The following is a description of a gene set: studied in species Mus musculus Any process that stops, prevents or reduces the frequency, rate or extent of intracellular signal transduction. Mouse Gene Set: GOBP_NEGATIVE_REGULATION_OF_INTRACELLULAR_SIGNAL_TRANSDUCTION, and this is the list of marker genes: Strn3, Rubcn, Igf1r, Sar1b, Ppp2r1a (NCBI Gene Id 76182), Dsg3, Prkdc, Nodal, Sla2, Cdc34, Csnk1a1, Gsk3b, Nme5, Pink1, Pttg1ip, Deptor, Smpdl3a, Hspa8, Kics2, Uchl1, Opa1 (OPA1, mitochondrial dynamin like GTPase), Bmp2, Ubr1, Gdf15, Cd44, Rnf152 (ring finger protein 152), Mecom, Map2k5, Dmd, Ifi203, C1ql4, Ufd1, Ppm1a, Ska1, Spi1, Cyrib, Tarbp2, Trim30a, Pde10a, Siglecg, Rasa2, Foxp1, Tmem161a, Myadm, Emilin1, Usp20, Minar1, Gpx1, Endog, Ska3, Tmc8, Trim15, Tpt1, Tnfaip3, Slc39a8, Arrb2, Magi2, Sfrp4, G2e3, Tbc1d7, Cptp, Gstp-ps, Rffl, Tkfc, Cyp2j6, Pdx1, Pebp1, Cavin3, Ifi208, Stk38, Pde2a, Drd3, Cep63, Zc3h12a, Atad3a, Ccn3, Dlg1, Aida, Vhl, Dusp7, Rps6ka6, Trim32, Ube3a, Nck1, Hipk3, Flcn, Arhgap24, Pkhd1, Grina, Vps18, Nop53, Tbk1, Foxo1, Usp10 (NCBI Gene Id 69204), Cdkn2a, Pten, Marveld3, Cyld, Nlk, Eid2, Cpne1, Them4, Fbp1 (NCBI Gene Id 14122), Prex1, Aars2, Smad4, Dynlt1b, Nr1h4, Wnk2 (NCBI Gene Id 75607), Spry4, Prkaca, Trem2 (NCBI Gene Id 83433), Nfe2l2, Dusp8 (dual specificity phosphatase 8), Stambp, Dusp26, Peli1, Btn2a2, Scai, Bcl6, Crebrf (NCBI Gene Id 77128), Tcf21, Ripk1, Igf1, Arhgap35 (NCBI Gene Id 65101), Rnf170, Ephb2, Eno1, Riok3, Sfrp2, Mefv, Tradd, Dyrk1a, Nlrx1, Ncor2, Akt3, Itfg2, Ski, Stmn3 (NCBI Gene Id 99032), Traf2, Lax1, Xbp1, Pik3ip1 (NCBI Gene Id 76083), Hdac3, Wtip, Tlr9, Armc10, Pik3r2, Ccar2, Ybx3, Tns3, Nf2, Dgkg, Fignl1, Heg1, Prkaa1, Pycard, Stat3, Dok2, Cd22, Tspan6, Inpp5k, Cnot9, Pdcd4, Uaca, Ndufa13, Pde3a, S2bpcox16 (synaptojanin 2 binding protein Cox16 readthrough), Veph1, Phb1, Sar1a, Slmap (NCBI Gene Id 83997), Cgnl1 (NCBI Gene Id 68178), Prdm15, Lilrb4b, Brca1, Pbp2, Rcan1, Rack1, Prkar1a, Szt2, Lilrb4a, Cdk5rap3, Lingo1, Psmd10, Errfi1, Prkar1b (protein kinase, cAMP dependent regulatory, type I beta), Ppp6c, Arhgap29, Nkiras2, Map2k3, Fhl2, Parp1, Pde11a, Trp63, Ifi207, Dyrk2, Hdac1, Zfp536, Wwc2, Pmepa1, Nono, Mapkap1, Rabgef1, Dhx58, Rnf149, Tmsb4x, Bag5, Dab2, Stmn1, Cyp26b1, Plekha1, D1Pas1, Park7, Ace2, Zdhhc12, Actn3, Spred2, Cnot1, Mad2l1bp, Cdkn2d, Fbxw11, Heyl, Rab7b, Abca7, Mif, Nppa, Hspb1, Lbh, Ifi206, Tnk1, Prkaa2, Ptgs2 (prostaglandin-endoperoxide synthase 2), Mir143, Dgkz, Huwe1, Tnip1, Rnf31, Tmem127, Wnt1, Adipoq, Rgs2, Cryba1, Rnf125, Selenos, C1qbp, Pik3cb, Trim31, Eno1b, Map2k1, Dusp6, Epm2a, Dusp2, Lyn, Hells (helicase, lymphoid specific), Spry2, Kank2, Ube2d1, Sh3glb1, Ddrgk1, P2rx7, Gstp1, Asxl1, Birc2, Ncor1, Edn1, Nlrp12, Cav1, Sesn2, Foxm1, Cmya5, Arhgap25, Xdh, Ptpn1, Ripor2, Ash1l, Prkcd (protein kinase C, delta), Nfkbil1, Itgb1, Drd2, Cry2, Nkiras1, Tgif1, Hdac7, Dnajb9, Ifi203-ps, Ppif, Ndrg2, Npc1, Prmt1, Bmal1 (basic helix-loop-helix ARNT like 1), Dusp5, Sco1, Hapstr1, Bfar, Inpp5e, Optn, Oprl1, Commd1, Serpine2 (serine (or cysteine) peptidase inhibitor, clade E, member 2), Insig2, Git1, Gper1, Eif2a, Ddx3x, Kdm1a, Dusp19, Ube2w (NCBI Gene Id 66799), Il1b, Parl (NCBI Gene Id 52663), Nol3, Wdr91, Arhgap42, Adra1b, Gata4, Mapk14, Mtor, Nck2, Shank2, Dok1, Myoz1, Ywhaz, Atad5, Stub1, Mob4, Gpatch3, Uri1, Itga3, Epo, Mndal, Fbxo7 (NCBI Gene Id 97657), Pbk, Muc1, Ikbkg, Dusp16, Pdia6, Mapk8ip1 (NCBI Gene Id 19099), Cilp, Tbc1d10c, Mapk3, Dusp13b, Lemd2, Cry1, Nlrc3, Otud3, Ddit4, Arrb1 (NCBI Gene Id 74110), Men1 (multiple endocrine neoplasia 1), Yju2, Rasip1, Src, Lmo3, Ifi35, Pp2d1, Ndufs3, Marchf7, Depdc5, Ogt, Dhrs3, Ucma, Vcp, Spred1, Cd74, Alg13, Smad7, Ndufc2, Timp2, Fam89b, Fzd1, Ptprc, Stat1, Pafah1b1, Rasal3, Triap1, Plaur, Phb2, Spred3, Clu, Cxcl12, Bdkrb2, F2rl1, Noc2l, Lztr1, Nherf4, Nprl2, Vdac2, Arhgap45, Ppia, Prnp, Cd300a, Aars1, Trim67, Sesn3, Castor2, Gpd1l, Ubqln1, Cntnap2, Rela, Smpd1, Lyplal1, Myoc, Prap1, Ppp1r10, Kctd10, Ptpn6, Ptprr, Rapgef1, Npy2r, Mapkapk5, Prex2, Dkk1, Cdc42se1, Erbin, Snai1, Mkrn2, Igtp, Trim39, Tnip2, Ppp2cb, Tsc2, Spaar, Gsk3a, Gmip, Sharpin, Cblc, Ackr3, Eif3a, Casp8, Gramd4, Isl1, Prkn, Pkia, Atf4, Ajuba, Ddias, Rtkn2, Chp1, Tnip3, Nfkbia, Ikbkb, Hyal2, Agt, Strip1, Irgm1, Atxn3, Cyp7b1, Abl1, Atf6b, Trim11, Prkacb, Hif1a, Sirpa, Trim59, Vrk3, Tnfaip1, Nlrp6, Aurka, Il10, Castor1, Creb3l1, Mmp9, Taok3, Nog, Tmbim6, Hmgcr, Snai2, Tsc1, Epha4, Plin5, Cul3, Sirt2, Sh2b3, Lif, Nfkbid, Homer2, Adgrg3, Tlr4, Egln1, Twist1, Vps11, Ell3, Dusp3, Sirt1, Plk3, Atp2b4, Styxl2 (serine/threonine/tyrosine interacting like 2), Sh3bp4, Gba1, Zmynd11, Nucb2, Map3k20, Rasal1, Thbs1, Zfp366, Slc24a4, Lrp1, Epha7, Mad1l1, Ptprj, Nploc4, Lpar1, Gstp2, Hmga2, Dusp10, Tank, Banf1, Limd1, Snip1 (Smad nuclear interacting protein 1), Ezr, Dusp29, Ripor1, Sema6a, Met, Dab2ip, Trex1, Nlrp3, Bcl2, Lamp2, Nmi, Slit2, Mir423 (microRNA 423), Foxh1 (forkhead box H1), Tnf, Smarca4, Kctd13, Prkar2a, Pdcd6, Fgf2, Hspa5, Grem1, Pparg, Fnip1, Oprm1, Mdm4, Pcbp4, Mfn2 (mitofusin 2), Chrna9, Herpud1, Dyrk3, Akt1s1, Cav3, Cnot2, Nup62, Sod2, Mstn, Ptpn2, Pde3b, Nherf1 (NCBI Gene Id 26941), Chrna7, Ezh2, Rgs14, Gcg, Sirt7, Kank1, Rora, Mtm1, Sh3bp1, Pin1rt1, Brd4, Sec14l1, Spry1, Rrm2b, Capn1 (calpain 1), Usp49, Ifi209, Cib1, Itch, Bcl2l12, Paqr3, C1qtnf3, Phlda3, Ppm1b, Arhgap17, Ddit3, Irak2, Azi2, Ctnnb1, Rnf34 (NCBI Gene Id 97276), Cdc34b, Nr1d1, Smad6, Ube2n, Syvn1, Pycr1, H2-M3, Cd2ap, Prkca, Fem1a, Synj2bp, Sfrp5, Ptprs, Nr0b1, Dusp1, Bid, Dgkd, Mark3, Zbtb7a, Atf3, Atm, Rrn3, Fkbp1b, Ube2b, Txndc12, Akt2, Arhgap12, Ccdc22, Irgm2, Cit, Rps6kb1, Lrrk2, Arhgap22, Itpr1, Ppef2, Cactin, Ifi213, Apc, Esr1, Clock, Smpd3, Gps2, Creb3, Sh3rf2, Wnk1, Nherf2, Olfm4, Adipor1, Dnaja3, Litaf, Nf1, Klf4, Aurkb, Usp47, Tle1, Pcbp2, Ranbp9, Rasa4, Ywhag, Ufl1, Chek2, Ankrd26, Zdhhc18, Prkar2b, Mgrn1, Usp7, Apoe, Dact1, Mapkbp1, Sirt3, Efna1, Dusp4, Rps6ka1, Ldlrad4, Gstp3, Mdm2, Trap1, Phlpp1, Bank1, Ppt1, Cnot3, Cnksr3, Kdm6a, Pias2, Ifi214, Spink1, Esr2, Tax1bp1, Trim60, Vgll4, Ern1, Calr (NCBI Gene Id 12317), Aplnr, Fyn, Rassf2, Eif2ak3, Psca, Fbxl2, Dlc1, Ubr2, Rbck1, Strn4, Tnfrsf1a, Ovol2, Homer3, Mul1, Hyou1, Aim2 (NCBI Gene Id 383619), Fktn, Insig1, Tgfbr3, Irak3, Dlg5, Otud7b, Ptpn22, Cgas, Dag1, Ivns1abp, Rnf167, Sesn1, Chuk, Zfp385a, Morn3, Ccdc125, Obscn, Kptn, Arhgap44, Pea15b-ps, Hdac2, Dusp9, Akt1, Klhl31, Sike1, Rhoh, Fbln1, Abl2, Mmp3, Myoz2, Sfrp1 (NCBI Gene Id 72362), Mapk7, Dnaja1, Bcl2l1, Tbx20, Stk11, Bmt2, Mtnr1b, Adra1a, Abhd17a, Znrf4, Tgfb2, Wfs1, Pin1, Hacd3, Nprl3, Ppp2ca, Wwc1, Lox, Chrna10, Per1, Spsb3, Tnfaip8l1, Qars1, E130311K13Rik, Rhoa, Syngap1, Csk, Ppara, Rasa3, Sbno1, Itgb1bp1, Bcl2l10